The following is a description of a gene set: studied in species Mus musculus A process in which a protein is transported to, or maintained in, a location within a microtubule organizing center. Mouse Gene Set: GOBP_PROTEIN_LOCALIZATION_TO_MICROTUBULE_ORGANIZING_CENTER, and this is the list of marker genes: Apc, Hook3, 4933427D14Rik, Mcph1, Bicd1, Cep250, Ccdc14, Numa1, Gsk3b, Cep131, Cep192, Cep350 (centrosomal protein 350), Pibf1, Nudcd3, Mark4, Mapre1, Rab11fip3, Cep63, Dctn2 (NCBI Gene Id 97666), Nsfl1c, Aurka, Disc1, Pcm1, Stil, Snx10, Pard6a, C2cd3, Cep78, Rab11a, Stk3, Trim69, Nup62, Cep83, Cep72, Htt, Bbs4, Ubxn2b, Csnk1d (casein kinase 1, delta), Spag5